The following is a description of a gene set: species: Homo sapiens from publication Jeffrey KL, Brummer T, Rolph MS, Liu SM, Callejas NA, Grumont RJ, Gillieron C, Mackay F, Grey S, Camps M, Rommel C, Gerondakis SD, Mackay CR (PMID 16474395) In the present study we used Affymetrix oligonucleotide microarrays to produce gene transcription profiles for the major leukocyte types in humans. This comprehensive dataset enabled us to not only establish which genes were expressed in each leukocyte type, but also which genes were expressed in each subset after activation. The used of a comprehensive dataset of gene profiles from all the major human leukocyte subsets enabled a novel and powerful means for identification of genes associated with single leukocyte subsets, or different immune paradigms. Genes down-regulated in comparison of mast cells versus B cells. Human Gene Set: GSE3982_MAST_CELL_VS_BCELL_DN, and this is the list of marker genes: DIDO1 (NCBI Gene Id 85362), ARL4C, UCP2, CLEC2D, DENND4B, PLAAT2, SLC7A6, COG7, NTAN1, NSUN5, SEZ6L2, UBE2J1, SLC37A1, THADA, MREG, TOP3B, ABCA7, TRPA1 (NCBI Gene Id 8989), DHX58, SFI1, SMC1A, ADK, PPFIBP1, KCNC4, SPINK2 (NCBI Gene Id 6691), SNN, MBL2, REPIN1, EBI3, SH2D3A, RAB36, FOLH1B, STS, MSL3, TP63, TCIRG1, ADCY8, SPTBN4, ATF7IP2, ZNF211, HLA-DRB6, PRSS16, SIRT7, NRXN1, CD40LG, LRRTM4, HOPX, SYNE1, SMPD3, SINHCAF, KYAT1, SNCG, KLHDC4, RGS3, GNA12, PDK1, SKAP1, IL15, INPP4A, CD72 (NCBI Gene Id 971), NT5E, NAA40, SMYD2 (NCBI Gene Id 56950), SLC25A28, CNTNAP2, WWC3, CKAP4, TOR1A, AMPD2, FCGR2B, KLHL25 (kelch like family member 25), H2BC7, ATP8B2, GTF3A, TRIM25, DUS2, SGPL1, SERINC2, PMS2P2, ZNF395 (zinc finger protein 395), URB1, PDP1, JAM3, MTSS1 (NCBI Gene Id 9788), RUBCNL, STK17B, IRF8, MAP4K2, PSME3IP1, FURIN, MPHOSPH8, ENTPD1, CCR7 (NCBI Gene Id 1236), SETBP1, FBXO41 (NCBI Gene Id 150727), ZCWPW1, IGLL3P, WDR82, CTCF, LIN37, IL27RA, CCDC198, RHOH, FAM30A, ALMS1, IRF4, SGSH, TRPV6, HLA-DRA, ADAR, FA2H, DENND3, TNFRSF13B, STUM, HLA-DRB1, JADE3, OAS2, LIG1, ZDHHC14, RARS2, GALNS, COQ8A, GDPD3, IL13RA1 (NCBI Gene Id 3597), PAX5, BCS1L, CHTOP, PPP1R2, GFOD2, EIF2AK3, CCNE1, EVL, POLR1G, CDR1 (NCBI Gene Id 1038), P2RY10, FCMR, PLD2 (NCBI Gene Id 5338), NMT1, BICD1, FMO1, RABGAP1, SARS2, MAGEF1, TRAPPC2, LRRK1, APOLD1, CTNNB1, GUSBP11 (GUSB pseudogene 11), CD48, PRORP, FCER2, KLF2, LSS, ETV4, CMTR1, ALOX12P2, BCL7A, PSME1, RAB4A, CD8B, JAK1, PDLIM1, ZNF586, PPP3CC, ABCB7, GABRB3, LAMB4, SYNE3 (NCBI Gene Id 79686), IL6, KLF8, NOP53, HLA-DMB, GLDC, PIP5K1B, GNL3LP1 (NCBI Gene Id 80060), KCNA3, PNRC1, TMUB2, C10orf95-AS1, CNTNAP3B, LCK, NAT8B, ARID5B, BTG1, FAM169A, HAUS2, HOXC4, UVRAG, HLA-DOB, SLC25A16 (solute carrier family 25 member 16), H2AC6, TMEM156, RTP4, TTC9, POLG, MX2, C1orf115